The following is a description of a gene set: An abnormality of platelets. studied in species Homo sapiens Human Gene Set: HP_ABNORMALITY_OF_THROMBOCYTES Abnormality of thrombocytes, and this is the list of marker genes: ALK, SMARCAL1, ATRX, OCLN, UQCRFS1, LAT (linker for activation of T cells), GP6, MS4A1, SAMHD1, RPL8, MAGT1, BCOR, RUNX1, VPS33B, NOTCH1, ZNFX1, XIAP, VWF, ADA2, TERC, RFXANK, SLC19A2, USB1 (U6 snRNA biogenesis phosphodiesterase 1), PTPRJ, CFHR1, ELANE, ACAD9, CYCS, PDGFB, RPS7, CTC1, DCLRE1C, DNAJC21, ASL, SH2B3, EPHB2, FANCD2 (NCBI Gene Id 2177), RAD51, GFI1B, FANCA, CALR, SKIC2, HMGCL, RNU7-1, NLRC4, RPS19, PTPN22, ACAT1, STIM1, SCN10A (sodium voltage-gated channel alpha subunit 10), APOE, ETV6, DGUOK, ASAH1 (N-acylsphingosine amidohydrolase 1), IL10, TNIP1, MYCN, COG4, GNE, GNA14, TRNT1, CBL, NBN, VPS45, PRKCD, SLC7A7, NOP10, PCCA, LMBRD1, CASP10, MMAA (NCBI Gene Id 166785), CFI, SCN11A, FCGR3B, BLK, SALL4, ABCC6, WAS, RPS26, MPL, IKZF1, RAG2, ELF4, NABP1, AP3B1, LZTR1, ESCO2, MYORG, TSR2, ZAP70, DZIP1L, VPS33A, COG6, TERT (NCBI Gene Id 7015), TGFB1, WRAP53, RAG1, MECOM (MDS1 and EVI1 complex locus), HLA-B, GATA1, SLC37A4, RPSA, PRF1, CISD2, STOX1, GBA1, UBE2T, BLOC1S5, SAT1, ITGB3, CORIN (NCBI Gene Id 10699), FARS2 (NCBI Gene Id 10667), FANCM, DTNBP1, CTLA4, TPM4 (NCBI Gene Id 7171), RBPJ, IL6ST, TBL1XR1, NAF1, RREB1, RBM8A, HPS4, C4B (NCBI Gene Id 721), PPIL1 (NCBI Gene Id 5482), FOCAD, CD81, DKC1, TUBB1, ADA, ITK, TINF2, MGAT2, PSTPIP1, GP1BB, TNFAIP3, PALB2, ORAI1 (ORAI calcium release-activated calcium modulator 1), SP110, PHGDH, TUBA8, LMO1, SAMD9, RNASEH2A, JAK2, XRCC2, HIRA, RFXAP (NCBI Gene Id 5994), PARN, TLR7, SEC61A1, CIITA, IRF1, SLC35A1, CLCN7, LYN, HACE1, RPS10, PMM2, SBDS, GALE, RARA (retinoic acid receptor alpha), RPS24, DNASE1, JAZF1, SPP1, PIK3CD, PDCD1, LIPA, OTUD5, OCRL, CFH, TNFRSF13B, ABCD4, ITGA2, SCN9A, LBR, TBXA2R, HEATR3, PML, SASH3, HLA-DRB1, C1GALT1C1, NFKB1, FCGR2C, CD19, CTNNBL1, SLF2, MED12, TBK1, MYH9, FANCC, RASGRP1, FANCB, ERBB3, RPS27, UNC13D, DEF6, RAD51C, ACD, CD46, RASA2, AFG2A, KIT, HELLPAR, CLPB, PLEKHM1, LACC1, RFWD3, TBXAS1 (NCBI Gene Id 6916), SMC5, USP18, SPRED2, SARS2, SCARB2, HMOX1, PRIM1, ARPC5, NUMA1, CR2, AGK, RPS14, IRAK1, ATP6V1B2, SAMD9L, PIGA, RPS17, ITGAM, ARPC1B, FCGR2B (NCBI Gene Id 2213), ADAMTS13, IVD, GCSH, HPS3, HOXA11, RFX5, DLL4, PLOD3, PHOX2B, ACTB, MAP2K1, STING1, TNFSF4, IFNG, PEPD, ARHGEF1, IFNGR1, NPM1, CUBN, ANKRD11, GIMAP5, SMPD1, HPS5, MARS1, PRKACG, WARS2, TBX1, POMP, SLC46A1, BRCA1, EPB42, JAM2, PLA2G4A, SEC24C, NIPBL, MYSM1, ACTN1, SF3B1, HLA-DQB1, ACP5, KIAA0319L, SRC, EFL1, SLC19A1, BTK, RTEL1, RPL15, STT3B, FIP1L1, FYB1, BLOC1S3, SMARCD2, UFD1, WIPF1, RPS28, PRKAR1A, TPP2, MTOR, DHFR, RPL27, GNAS, CRELD1, FAS, RNASEH2B, PNP, DOCK6, ABCG8, MMAB, PLAU, POT1, FANCI, PSAP, ATP6AP1, NFKB2, FASLG, BTNL2, POLRMT, IGHG1, P2RY12, NLRP3, NBEAL2, APOA1, THBS2, STAT4, TNFRSF13C, CD40LG, FOXP3, LARS2, WFS1, HSCB, IKZF5 (IKAROS family zinc finger 5), LIG4, CFB, ANKRD26, MTHFD1, RPL9, KCNJ1 (potassium inwardly rectifying channel subfamily J member 1), ASXL1, WDR1, THBD, RECQL, LCK, STXBP2, KIF15, RPS20, STAT2, RAF1, RAP1B, FLT1, NRAS, COMT, IL7R, NHP2, RPS29, SRSF2, G6PC3, CD55, TALDO1, DOCK2, CA2, BCR, ITGA2B (NCBI Gene Id 3674), RPL35A, ABCG5, RPL26, RASGRP2, ARHGAP31, CDC42, MADD, RYR1, PKHD1, OSTM1, SOCS1, DGKE, TCIRG1 (T cell immune regulator 1, ATPase H+ transporting V0 subunit a3), COG1, TREX1, BANK1 (B cell scaffold protein with ankyrin repeats 1), IRF2BP2, SC5D, MMACHC, RPL31, PTPN11, RPL5, SRP54, IRF8, GUCY1A1, ETS1, PCCB (NCBI Gene Id 5096), RNASEH2C, JMJD1C, TNFSF11, MMUT, REL, IFIH1, EOGT, HLA-DQA1, HLCS, LSM11, FANCG, KRAS, ARVCF, SH2D1A, FLI1, SKIC3, C3, MOGS, MRAS, PRDX1, NSUN2, HBB, CD36, BLOC1S6 (biogenesis of lysosomal organelles complex 1 subunit 6), BRAF, RPS15A, PDGFRB, KDM6A, GP1BA, RIT1, TNFSF12, TET2, ABL1, TLR8, ERCC4, ALG8, NAA10, STAT3, BRIP1, LCP2, CDC40, KMT2D, GALC, FANCE, UBE2L3, PIK3CG, PSMB4, STAT5B, LYST, SOS1, BRCA2, LIN28B, ZBTB16, ADAR, RPL18, SRP68, IRF5, THPO, RRAS, ENPP1, TP53, MVK, KCNN4, C4A, ABCA1, MECP2, LRBA, HPS6, FANCL, MAD2L2, P4HA2, ADH5, TYMS, MPIG6B, UBA1, UROS, RPL11, KARS1, PXK, ICOS, TMEM165, STAT1, SLX4 (NCBI Gene Id 84464), XPR1, GATA2, DOCK11 (dedicator of cytokinesis 11), CD109, ATP7B, GP9, TFRC, SOS2, ERCC6L2, SLFN14, ALG12, AMN (amnion associated transmembrane protein), FANCF, SLC39A7, FCGR2A, RRAS2, RPL35, DIAPH1, SNX10, NOS3, TBC1D24, FLNA (filamin A), TCN2, TTC7A, COL4A5, FERMT3, PSMB8, CFHR3 (complement factor H related 3), STX11, SLC20A2, NHEJ1